The following is a description of a gene set: The process in which a relatively unspecialized hemopoietic precursor cell acquires the specialized features of a leukocyte. A leukocyte is an achromatic cell of the myeloid or lymphoid lineages capable of ameboid movement, found in blood or other tissue. species: Homo sapiens Human Gene Set: GOBP_LEUKOCYTE_DIFFERENTIATION, and this is the list of marker genes: RNF41, BMP2, ADA, FOXN1, NDFIP1, LCK, NEDD9, CD79A, ZBTB1, DNAJA3, MSH2, EGR1, GPR68, CEBPG, IFI16, TMEM176B, NFKBIZ, CD80, HLX, FCER1G (NCBI Gene Id 2207), SOCS3, IL1RL1 (NCBI Gene Id 9173), AGER, FBN1, AP3B1, RPL22, SLC4A2, VSIR, MFNG, MS4A1, PPP3CB, GLI2, SASH3, CTLA4, IL18R1, TGFBR2, BAK1, PIAS3, TNFRSF11B, MYB, SLC46A2, GATA2, GPR18, FOXO3, IL2, IL10, SMARCD2, HSF1, GPR137, CALCA, PIK3R3, ANXA1, IL5, PIK3R6, TREM2, LGALS3, CMTM7, TESC, AP3D1, C17orf99, FCRL3, RUNX1, IL23R, SP3, CFLAR, INPP5D, BTN2A2, FASN, SH3RF1, ABL1, SYK, L3MBTL3 (L3MBTL histone methyl-lysine binding protein 3), RB1, FGL2, SMARCD1, IL33, IFT80, IL23A, RELB, FOSL2 (NCBI Gene Id 79579), HLA-DOA, MEN1, ICOSLG, KAT7, BATF3, LGALS9, NKX2-3 (NCBI Gene Id 53631), FBXW7, IL12RB1, SPI1, LGALS1, CD19, CREB1, SMARCB1, OPA1 (OPA1 mitochondrial dynamin like GTPase), TFRC, PTPRJ, RORC, LGALS8, JAK1, CAMK4, LILRB1, SMARCE1, PNP, IL18, POU4F1, NFKBID, CBFA2T3, PTCRA, PLCL2, BRD4, IL12B, ITGA4, BTK, NKAP (NCBI Gene Id 79576), WNT10B, KIT, CYLD, CHD7, YY1, FES, ZFPM1, CR1, PPARGC1B, FZD9, LBR, VNN1, RORA, CD3E, LIG4, VPS54, KDELR1, BATF2, CDKN2A, CASP8, CLPTM1, TAOK3, RBPJ, CCR6, KMT2A, BATF, GPR55 (NCBI Gene Id 9290), IHH, CD1D, CD74, ATG5, PRKCZ, STK11, GAB2, CTSL, CEBPA, ACTL6B, ZNF683, ADAM10, CEACAM1, SMARCC1, ST3GAL1, PRDM16, SPIB, SIGLEC15, C1QC, RHOA (NCBI Gene Id 387), BRD2, SLAMF1, VAV1, TGFB1, PIK3CD, SIRT1, SHB, USP44, HLA-G, IL4, SOX12, KLF6, TYRO3, HLA-DRB1, PCK1, EIF2AK1, AMBRA1, CD46, MITF, GPR89B, SRP54, CARD11, PRR7, CLPB, APCS, FBXO7, FANCA, DOCK2, ARID3C, DOCK11, CARTPT, CRTAM, EPHA2, BAP1, TNFSF9, KLHL25, IL6 (NCBI Gene Id 3569), POU4F2, BCL3, UBASH3B, TNFSF11, AXL, CD81, PARP1, TF, SLAMF6, SBNO2, FOS, IKZF1, DCSTAMP, AQP8, MR1, PTK2B, CCN4, LRRC17, TLR3, CCR1, COA5, PRDM1, TSC1, PSMB11, ITFG2, MIR21, NRROS, IL36B, CITED2, ERBB2, FZD8, TOX, GPS2, F2RL1 (NCBI Gene Id 7901), OSCAR, ZBTB16, PPARG, CD3D, DLL1, BCL11B, ITGB8, TMEM178A, CD4, TOB2, JUNB, LOXL3, SLC39A7, IL4I1, GAS6, SMARCC2, IRF2BP2, FARP2, LILRB3, FUT7, ACIN1, BRD7, ZFP36L1, HLA-B, SYVN1, IL9, BRAF, FNIP1, TPD52, SRC, MED1, CTNNB1, RIPK1, RC3H2, CBFB, ANXA2, DCAF1, MYD88, CCL3, HHEX, IL6R, ARMC5, PRKDC, KLRC1, QKI, ARID1B, TRAF3IP2 (TRAF3 interacting protein 2), ZAP70, GPR89A, ZC3H12A, ATF2, FLT3, IFNG, BGLAP, LIF, RIPK2, STAT6, ZFP36L2, CCR7, ATP6AP1, NFATC3, INHA, ARID1A, LEPR, SH3PXD2A, TNFSF13B, PRKCA, TLR4, STAT5A, NOTCH2, TNFSF18, IL21, CSF3, IL2RG, CALCR, IRF7, NPM1, IL34, RARA, MTOR, TMEM64, PBRM1, MIR30B, JAGN1, AICDA (NCBI Gene Id 57379), ONECUT1, IFNL1, SLC25A5, LFNG, NHEJ1, IRF8, IAPP, KAT2A, ACTB, RSAD2, ADAM8, NFIL3, SOX4, MYH9, CLEC4E, CSF1, ICOS, EVI2B, LMBR1L, DDRGK1, GPR183, RHOH, PIR, LYN, EZH2, FAM3C, CDH17, TLR2, THEMIS, PATZ1 (NCBI Gene Id 23598), TSPAN2, FZD5, TRAF6, IL7R, LYL1, TMEM176A, TM4SF19, AZI2, IL27, SART1, TMEM131L, OSTM1, GATA3, PIK3R1, SOCS5, XRCC6, RRAS, EP300, IGHM, PGLYRP3, ATP7A (ATPase copper transporting alpha), LRRK1, LILRB2 (NCBI Gene Id 10288), TNFRSF9, BCL6, POLM, STAT5B (signal transducer and activator of transcription 5B), DCLRE1C, RASGRP1, RABL3, CEBPB, MIR486-1, HMGB3, ITGB1, NTRK1, NRARP, PHF10, BAX, NCKAP1L, DIAPH3, LY6D, JAK3, TRPM2, CD83, CSF1R, CLDN18, HCLS1, GPR137B, CYP26B1, TOP2B, ID2, CR2, RC3H1, TMEM98, IL31RA, HOXA7, ZNF675, PTPRC, CSF2, CLEC4G, MIR223, DUSP10, PCID2, STAT3, TNFRSF11A, HDAC4, NDP, NLRP3, SMARCA2, ZMIZ1 (zinc finger MIZ-type containing 1), ENTPD7, RIPK3, CCL19, SOX13, JUN, IREB2, MDK, HDAC9, FSTL3, ZC3H8, ZEB1, VCAM1, JAG2, TNF (tumor necrosis factor), PSEN1, CUL4A, PRXL2A, GPC3, PREX1, TBK1, HDAC5, PTPN6, TCF7, SPINK5, CDC42, PF4, FOXP3, ZBTB7A, MFSD8, MAFB, IL25, TBX21, SRF, SMARCD3, POU2AF1, IRF1, MYC, BMI1, ASCL2, DROSHA (drosha ribonuclease III), MIR125B1, BLNK, FSHR, FLT3LG, CD8A, EGR3, CLEC4D, TCF3, UCP2, ZBTB46, PLA2G3 (NCBI Gene Id 50487), TFE3, EEIG1, NR3C1, ITPRIPL1, RUNX3, WNT4, HLA-DRA, MIR17HG, TLR9, TRIB1, OCSTAMP, PAX5, NAGLU, SEMA4A, CLCF1, NCAPH2, ITGB6, RAG2, GAB3, NFAM1, TP53, MMP14, FOXJ1, LAG3 (NCBI Gene Id 3902), DLL4, APP, TNFSF4, FCGR2B, FOXP1, KITLG, PLCG2, IL15, THOC5, ARID2, IGSF23, COX10, EFNA2, SMAD7, LAPTM5, IKZF3, CRACR2A, PTPN2, MMP9, VEGFA (NCBI Gene Id 7422), PKNOX1, ERFE, ITK, CTNNBIP1, RAG1, HMGB1, RUNX2, IL7, MERTK, DTX1, MT1G, ACTL6A, IL2RA, MALT1, GPR65 (G protein-coupled receptor 65), IL1A, PBX1, ATM, ADGRG3, KLF10, MIR145, CD69, IL15RA, LARGE1, PRELID1, PTGER4, ADAM17, SOS1, IL11, CD40LG (NCBI Gene Id 959), PGLYRP2, CD2, IL4R (NCBI Gene Id 3566), LEP, CD28, CD3G, GATA1, FAM20C, PGLYRP1, INHBA, PDE2A, CD79B, SLC9B2, CD86, LILRB4, B2M, TUSC2, DHRS2, PPP3CA, DNAJB9 (NCBI Gene Id 4189), GLO1 (glyoxalase I), WNT1, GBA1, P2RX5, TYROBP, IL6ST, SFRP1 (NCBI Gene Id 6422), METTL3, ITPKB, TNFAIP6, FSHB (NCBI Gene Id 2488), SHH, PDE1B, LTBR, CD101, TET2, GLI3, KCNK18, IFNB1, EOMES, MAPK14, IRF4, DOCK10 (dedicator of cytokinesis 10), PRTN3, PAFAH1B1, PIK3R2, CEBPE, BAD, IL20, LIPA, TAL1, CLEC12A, NF1 (neurofibromin 1), LY9 (lymphocyte antigen 9), HAX1 (HCLS1 associated protein X-1), IGHE (immunoglobulin heavy constant epsilon), IL1B, BCL2, PDP2, SOS2, IFNA2, IL1RL2, TCTA, JMJD6, KAT5, ZBTB7B, CCDC39, PLA2G2D, FADD, CD109, FANCD2, SOCS1, VPS13A, PRDX2, SMARCA4, PSG9, PPP2R3C, CDK6, XBP1, IL17A, LTF, STAT4, TCIRG1, PTPN22, ITM2A, LRRC8A, PHF14, FZD7, ADIPOQ, SPN, CCR9, RASSF2, CCR2, CD27, LEF1, BBLN, UBD, AIRE, RPTOR, SOD1, TESPA1, SNX10, TNFSF8, SLAMF8, BMP4 (NCBI Gene Id 652)